The following is a description of a gene set: part of: Peptide hormone metabolism species: Mus musculus electronically inferred by orthology from the curated human pathway This event has been computationally inferred from an event that has been demonstrated in another species.<p>The inference is based on the homology mapping from PANTHER. Briefly, reactions for which all involved PhysicalEntities (in input, output and catalyst) have a mapped orthologue/paralogue (for complexes at least 75% of components must have a mapping) are inferred to the other species. Reactome Pathway: Incretin synthesis, secretion, and inactivation, and this is the list of marker genes: Ffar1, Gnat3, Gcg, Gip, Gnb3, Lep, Dpp4, Grp